The following is a description of a gene set: Human Gene Set: HP_PROGRESSIVE_MUSCLE_WEAKNESS Progressive muscle weakness studied in species Homo sapiens, and this is the list of marker genes: MFN2 (mitofusin 2), TTN, DYSF, NEB, PEX2, VAPB, DOLK, PCNA, PEX5, TPM3, TRAPPC11, MT-TE, TNNT1, TWNK, ACTA1, CRYAB, LTBP4, PEX13, TK2, GGPS1, PEX14 (NCBI Gene Id 5195), BIN1, PHKG1, MIEF2, SMCHD1, PHKB, DNMT3B, ANO5, PUS1 (NCBI Gene Id 80324), MEGF10, TBCK, MAP3K20, HACD1, DES, MYOT, TPM2, MYH7, ITGA7, RILPL1, GOSR2, POLG2, NOTCH2NLC, COL12A1, PEX10, SPEG, ABHD5, SELENON, COL6A3, MYL2, POLG, LDB3, PEX11B, PEX1, MT-TL2 (NCBI Gene Id 4568), MT-TN, DUX4L1, FRG1, PEX16, SIL1, PHKG2, PEX26, MT-TL1, PEX12, VCP, PHKA1, PEX6, GIPC1 (GIPC PDZ domain containing family member 1), PYGM, FKTN, DUX4, COL6A1, DMD, PNPLA2, TPI1, LRP12, MLIP, AHDC1, MPV17, PEX19, COL6A2, RYR1, COQ2, PLEC, PHKA2, PRPS1, SPTLC1, PEX3